Given this list of marker genes Rnd3, Morc2a, Amotl1, Sh3tc2, Tln2, Fam81a, Chchd3, Kdelr1, Naa50, Proser1, Ildr2, Fut8, Wbp1l, Rpl7l1, Ralbp1, Cdkn1b, Arhgap20, Rab39, Syn1, Hspd1, Zfp984, Pcsk2, Mesp2, Phactr3, Nab1, Mapk10, Rnmt (NCBI Gene Id 67897), Eif4e, Taf12, Xlr3c, Igfbp5, Zfp160, Vamp1, Pltp, Lipt1, Tor1aip1, Erc1, Pbdc1, Zfp934, Zmynd8, Neto1, Ran, Mfsd4b5, Epha7, Msr1, Cramp1 (NCBI Gene Id 634722), Tmem132b, Metap1, Zfp704, Ubn2, Slc4a10, Itgb3, Ddx4, Grin2b, Nrxn1, Tlcd4 (TLC domain containing 4), Krtap16-3, Ccdc68, Zfp652, Pou2af2, Alpk3, Fndc9, Bhlhe40, Thrb, Ubxn7, Osbpl3, Znrf1, Gpn2, Tfdp2, Cfap97, Cd200r3, Kars1, Zfp109, Rnase10, Rwdd4a, Sdc3, Csmd1, Mapre2, Ndufaf5, Tmem178b, Ttll4, Galt, Plcxd2, Ifnar1, Sltm, Zfp444, Rad54b, Mat2a, Dennd2a, Ehd4, Creg2, Prkcq, Klhl11, Tmem30c, Oprk1, Ctsm, Lrp8 (low density lipoprotein receptor-related protein 8, apolipoprotein e receptor), Wsb1, Ccdc82, Mtus2, Galnt2, Ankrd34b, Skint3, Myoz3, Sertad2, Eif4e3, Chek1, Ormdl1, Adora2a, Mapt (NCBI Gene Id 17762), Lrrc15, Xlr3a, Adgrf5, Ttll7, Il17rb, Cdh20, Tasor, Spag11b, Cdk6, 4933411K16Rik, Ccdc85a, Sfxn4, Zfp987, Xlr3b, Mbd1, Stradb, Phactr2, Cts3, Zfyve26, Oprd1 (NCBI Gene Id 18386), Hivep3, Celf1, Mex3a (mex3 RNA binding family member A), Jmy, Ric3, Gm128, B4galt6, Tmed8, Ddx6, D830030K20Rik, Zfp780b, D3Ertd751e, Mgat3, F11r, Fxr1, Zfp462, Olfml2b, Cd83, Clasp2, Tcp1, Dcaf5, Erlin1, Rnf115, Ntm, Zfp268, Dgkb, Secisbp2l, Pde1a, Prkg1, Npas2, Lmna, Cyfip2, Dag1, Gcn1, Col19a1, Pif1, Arpc5l, here is a description of the gene set: from publication Chen Y, Wang X (PMID 31504780) species: Mus musculus Mouse Gene Set: MIR_12202_3P Genes predicted to be targets of miRBase v22 microRNA mmu_miR_12202_3p in miRDB v6.0 with MirTarget v4 prediction scores > 80 (high confidence targets).